Given this list of marker genes SYT11, DPYSL4, ARL6IP1, ST6GAL1, ACP2, TERF2, ARF1, CDCP1, SYNGR1, KRTAP19-5, RPL14, ST8SIA3, PTPRB, SSNA1, IPO11, TNF, CSF2RB, PROCR, TMEM40, NR1H3, CD1D, NDUFV3, TPP1, SPN, NDUFA12, TAF11, PTPN23, NUDT3, APP, HLA-G, PRSS8, SLFN12L, LCP2, TOM1, MAFB, PGM1, PDE1B, C1QA, AVIL, ZSCAN26 (zinc finger and SCAN domain containing 26), IL18, C1QC (complement C1q C chain), F11R, TXNDC12, CINP, MYL12B, FGF5, ATP6V1D, RBM4B, HFE, SLC29A1, MFSD1, EXOSC10, DFFA, DLG1, SMTN, ATG13 (NCBI Gene Id 9776), CCND2, COPZ1, PIP4K2A, PNPO, HESX1, WNT5B, SWI5, POM121, GBP2, INTS6, PHETA1, ASCL2, PTCH2, GAS6, VPS29, RASSF2, ADAM23, TNIP1, PHPT1, C1QTNF1, CD81, GNGT2, FAM114A2, DPCD, RAB34, NAA60, SPINT1, USP18, FBRS, GSX1, PRRC1, ANKRD40, RPL7L1, ESR1, PHTF1, OMD, SUPV3L1, G6PD, HOXC4, SUGT1, CD5L, PRPF31, FABP7, MRPL23, UFD1, ANGEL2, PHF12, HDDC2, SCMH1, GTF2F2, PRDX6, MRPL27, CYB5B, GNAS-AS1, YIPF1, DCLRE1A, NPC1 (NPC intracellular cholesterol transporter 1), PDGFB, ADCY7, TXNIP, PCBP2, STXBP3, SEC11C, NUDT1, MAPK14 (mitogen-activated protein kinase 14), MNS1, DNASE1L3 (deoxyribonuclease 1L3), ACTN2, STAT1, UCP1, FUT4, CANT1, WASF2, CLIC3, ZNF32, PSENEN, NAPA (NSF attachment protein alpha), SOAT1, MICOS13, DMD, METTL3, HBE1, KRT1, INTS9, ECHS1, PDRG1, PRM3, PAN2, PBX2, PHF13, SESN1, LHX8, PCSK7, UQCC1, TM2D3, LAGE3, CNDP2, LPCAT1, RCN3, SERPINB2, SHF, JADE1, ZEB1, OS9 (OS9 endoplasmic reticulum lectin), RETN, CD300C (NCBI Gene Id 10871), TTC1, FOXK2, ZFR2, SCGB1A1, SIRPA, ARPC3, AGRN, SPAG5, RAD50, MIA3, UFC1, LY9, SYT2, VAMP8, ZFP1, AMBRA1, ACP5, TENM1, CBL, CAPZB, ARHGAP35, STK38, C1orf43, PTPN21, PDCL3, MSL1, CHADL, RTCB, MC1R, TRIM21, EEF2K, LSP1, MXD4, TRAFD1, SEC63, ARHGEF25, NOG, here is a description of the gene set: studied in species Homo sapiens from publication Edwards AD, Chaussabel D, Tomlinson S, Schulz O, Sher A, Reis e Sousa C (PMID 12816982) Genes up-regulated in comparison of CD4 dendritic cells (DC) versus CD4- CD8- DCs. Human Gene Set: GSE339_CD4POS_VS_CD4CD8DN_DC_UP The functional relationships and properties of different sub-types of dendritic cells (DC) remain largely undefined. We used a global gene profiling approach to determine gene expression patterns among murine splenic CD11c high DC subsets in an effort to better characterise these cells.